Given this list of marker genes GCH1 (GTP cyclohydrolase 1), SYT1, TNIP1, PITX3, MMUT, PSMC1, VAMP2, FBXO28, FCGR2B, ATXN1, ERCC6 (ERCC excision repair 6, chromatin remodeling factor), TBP, GNAO1, PRRT2, FOXG1 (NCBI Gene Id 2293), TTI1, SPR, GABRA2, CACNA1A, MT-ND3, SLC16A2, TNFAIP3, CLPB, ITGAM, CERS1, TMEM151A, PDGFB, PDE2A, MED23, IREB2, XPR1, FBXL4, GPR88, CARS2, PDCD1, ADA2, SPOP, JAZF1, U2AF2, MECR, WARS2, GRM7, IGHG1, HCFC1 (NCBI Gene Id 8267), IL10, BANK1, GABRG2, PNKD, SH2B1, APTX, HPRT1, TLR7, NDUFA1, MRE11, LRPPRC, CACNA1B, GAMT, UGDH, IRAK1, ATXN7 (NCBI Gene Id 6314), PDE10A, CHKA, PSAP, XK, LONP1, XPA, SIK1, SUCLG1, SLC4A10, GON7, ATP1A2, CASK, ATP7B, MT-TV, JPH3, TRPM3, DMXL2, DNASE1 (deoxyribonuclease 1), ATN1, TIMM50, C4A, MT-TK, HSD17B10, RNU4-2, ATP7A, ATP1A3, GM2A, NAXD, RHOBTB2 (NCBI Gene Id 23221), SHQ1, NUP54, ITPR1, DDC, ABHD16A, TNFSF4, KIF1C, MICOS13, SLC13A5, HSPD1, PDHA1, NGLY1, UBTF, MT-ND6, MT-TW, SLC1A3, KCNN2, GLYCTK, ERCC2, TYROBP, HLA-DRB1, QDPR, ALS2, TSEN2 (NCBI Gene Id 80756), MYORG, TOE1, PNKP, SCN1A, GRIA4, TREX1, SLC6A8, CHMP1A, KIAA0319L, SLC25A22, PIGP, MT-ND5, FUS, PNPT1 (polyribonucleotide nucleotidyltransferase 1), FCGR3B, MT-ATP6, KCNA1, TREM2, ATP5MK, ACP5, SPP1, PTS, PDGFRB, ARX, FRRS1L, CIC, KCNMA1 (NCBI Gene Id 3778), TSEN15, DYSF, CR2, SPG11, GRIN2B, MT-ND4, NEUROD2, ATG7, UBE2L3, POLG, SPTBN4, DCAF17, PLA2G6, DPYSL5, SCN2A (NCBI Gene Id 94312), NDUFA13, KIF5A, ETS1, MRPS34, CDKL5, TUBB4A, PXK, PANK2, GJC2 (NCBI Gene Id 57165), BLK, TSEN54, VPS4A, SLC2A1, PIK3R5, IRF5, COX20, DLAT, ARSA, STXBP1, SCN8A, DHX30, EIF2AK2, GRIK2, CTDP1, ADAR, ELP2, ADCY5, GRIA2, MRM2, FXN, NAA60, RNF216, ATXN2 (NCBI Gene Id 8095), SLC19A3, SUOX, NPTX1, GCDH, FTL, NDUFAF5, POU3F3, SLC6A3, MECP2, SLC20A2, SLC32A1, AARS1, TAF1, C4B, MT-ND2, PLP1, GRIN1, SEPSECS, ACAT2, MT-ND1, ZNF142, SLC30A9, ST3GAL5, CTLA4, STUB1, GUF1, CLCN4, PTPN22, NADK2 (NCBI Gene Id 133686), HTT, NUP62, TSEN34, SETX, PIGN, SLC25A42, AP2M1, NKX2-1, STAT4, TMEM106B, ATM, CACNA2D1, CACNA2D2, SCN1B, TRIM8, SIGMAR1, TNR, IRF2BPL (NCBI Gene Id 64207), PRNP, SLC2A3, NDUFA9, TRAPPC11, GTPBP2, SPTLC1, OPA3, MT-TL1, CP, MICU1, AP1S2, GNAS (NCBI Gene Id 82944), PIGQ, VPS13A, here is a description of the gene set: species: Homo sapiens Human Gene Set: HP_CHOREA Chorea Chorea (Greek for 'dance') refers to widespread arrhythmic involuntary movements of a forcible, jerky and restless fashion. It is a random-appearing sequence of one or more discrete involuntary movements or movement fragments. Movements appear random because of variability in timing, duration or location. Each movement may have a distinct start and end. However, movements may be strung together and thus may appear to flow randomly from one muscle group to another. Chorea can involve the trunk, neck, face, tongue, and extremities.